Given this list of marker genes RNF148, PARD3B, RHOA, ATP5F1B, THEMIS, ELF4, SLC25A47, VTA1 (vesicle trafficking 1), CDH26, EXOC5, MUC4 (mucin 4, cell surface associated), PANK2 (NCBI Gene Id 80025), ME2, CHSY3, PEPD, MISP, GPATCH2, F2, EFHC2 (EF-hand domain containing 2), DOC2B, APOL2, STK39, ABHD18, RILPL1, ITPR2, ANGPT1, CCR8, MBLAC1, ZNF879, TIAM2, GNG11 (G protein subunit gamma 11), TSPAN9, NPAS1, SKIL, DGLUCY, GPM6A, RPS6KA2, RGL1, PDZK1 (NCBI Gene Id 96133), CARNMT1, VMAC, PLS3, GDAP1L1, ZNF679, PGK2, JAK1, NKAIN4, MGAT4B, NEFL, ACSL3, HAO1, CACNG3, RCAN3, CYP2R1, SPMIP6, PRKACB, MIR1915HG, DDX5, TOX3, SLC16A12, BRME1, FUT9, PTPN13, CPLANE2, CRTAM, MBTPS1, SCAF11, ZGRF1, SESTD1, TMEM80, AIRN, SDR42E1, CD163, IGSF3, CCDC14, JRK, TTC28, TNPO1, CHDH, ADAM11, SLC35C1, ABRAXAS1, WDR13, RPS3A, ADAMTS6, SUPT7L, ARL4C, NKTR, FADS6, ZNF687, PNLDC1, FZD10, ING5, PLA2G4A, CYTL1, NCMAP, ZNF821, ABCA4, SLC15A1, SPECC1, GPD2, TRMT10C, CTRC, FABP2, NOP14, IL6R, CDH13, C4B, ZNF397, TGFBR3, PLA2G4F, CWC27, BPGM, SPG11, PALLD, IRX1, ST3GAL1, CRX, CEP135, SMOC2, LYZL6, IL4, CTNNB1, VPS9D1, ZCCHC24, RC3H2, CKAP2, DDHD2, ADCY10, SLC16A5, SF3B4, GSK3A, F2RL2, C6, GPR22, CUTC, PRSS12, SPACA9, DYNLT5, AGT, REXO5, UXS1, KCNIP1, SCG2, TMEM199, VIPR1, FUT11, MEIKIN, PDE7B, TPBG, CNOT7, IGF2R, AKAP4, OVGP1, PDYN, LOX, ILDR1, MEGF6, AREG, ARPC5, FBXL3, PCDHB10, MEF2A, CFAP299, LIPN, TRARG1, UBASH3B, B3GNTL1, ZC3H6, GMEB2, SLF1, VAMP1, PPP6R3 (protein phosphatase 6 regulatory subunit 3), ACOXL, HAUS5, JPT1, C6orf141, CTSW, ZNF644 (NCBI Gene Id 90858), PIGG, COPRS, TELO2, FAIM, ENSG00000267882, DRC1, CCNF, APOBEC4, KRT33A, STAR, ANXA6, PTGFRN, TCF20, NHLRC1, PRKAG2, BCDIN3D, ADD3, SHC4 (NCBI Gene Id 399694), ANTKMT (NCBI Gene Id 82377), ATOSA, here is a description of the gene set: Human Gene Set: GSE369_SOCS3_KO_VS_IFNG_KO_LIVER_UP from publication Croker BA, Krebs DL, Zhang JG, Wormald S, Willson TA, Stanley EG, Robb L, Greenhalgh CJ, Förster I, Clausen BE, Nicola NA, Metcalf D, Hilton DJ, Roberts AW, Alexander WS (PMID 12754505) Changes in mouse liver mRNA profiles following intraperitoneal cytokine injection. Either interferon-gamma-/-, albumin-cre(-) Socs3(w/fl) mice, or albumin-cre(+) Socs3(-/fl) mice were injected with either phosphate-buffered saline, interferon-gamma, or interfeukin-6, and livers taken after 4h. Genes up-regulated in liver with knockouts of: SOCS3 versus IFNG. species: Homo sapiens